Given this list of marker genes Cd84, Foxf1, Cd300a, Il13ra2, Hmox1, Rabgef1, here is a description of the gene set: Any process that stops, prevents, or reduces the rate of mast cell degranulation. studied in species Mus musculus Mouse Gene Set: GOBP_NEGATIVE_REGULATION_OF_MAST_CELL_DEGRANULATION